The following is a description of a gene set: species: Mus musculus Mouse Gene Set: REACTOME_REGULATION_OF_ORNITHINE_DECARBOXYLASE_ODC Regulation of ornithine decarboxylase (ODC), and this is the list of marker genes: Psmc4, Psmb1, Psmc3 (proteasome (prosome, macropain) 26S subunit, ATPase 3), Oaz1, Nqo1, Psma2, Odc1, Psmc2, Psmd6, Oaz3, Psma3, Psmd7, Psmb3, Psmd14, Psmc6, Psma6, Oaz2, Psma5, Adrm1, Psmd8, Psma4, Psmb5, Psmd11, Psmd1, Psma1, Psma7, Psmb2, Psmd13, Psmc1, Psmb4, Azin1, Psmd3, Psmd12, Psmb6, Psmd2 (NCBI Gene Id 77434), Psmc5 (protease (prosome, macropain) 26S subunit, ATPase 5), Psmb7